The following is a description of a gene set: Ageing of the brain leads to impairments in cognitive and motor skills, and is the major risk factor for several common neurological disorders such as Alzheimer disease (AD) and Parkinson disease (PD). Recent studies suggest that normal brain ageing is associated with subtle morphological and functional alterations in specific neuronal circuits, as opposed to large-scale neuronal loss. In fact, ageing of the central nervous system in diverse mammalian species shares many features, such as atrophy of pyramidal neurons, synaptic atrophy, decrease of striatal dopamine receptors, accumulation of fluorescent pigments, cytoskeletal abnormalities, and reactive astrocytes and microglia. To provide the first global analysis of brain ageing at the molecular level, we used oligonucleotide arrays representing genes to determine the gene-expression profile of the ageing neocortex and cerebellum in mice. Ageing resulted in a gene-expression profile indicative of an inflammatory response, oxidative stress and reduced neurotrophic support in both brain regions. At the transcriptional level, brain ageing in mice displays parallels with human neurodegenerative disorders. Caloric restriction, which retards the ageing process in mammals, selectively attenuated the age-associated induction of genes encoding inflammatory and stress responses. Mouse Gene Set: LEE_CALORIE_RESTRICTION_NEOCORTEX_UP species: Mus musculus from publication Lee CK, Weindruch R, Prolla TA (PMID 10888876) Up-regulated in the neocortex of aged (30-month) mice subjected to caloric restriction since young adulthood., and this is the list of marker genes: Anxa6, Slc12a2, Pura, Hint2, Naa80, Zfp771, Zbtb7a, Lonp1, Gpr19, Samhd1, Gabra2, Acta1, Stk39, Hoxa6, Khdrbs1, Hoxb9, Slc6a15, Cnot2, Hoxb3, Dtna, Tnnc1, Fabp5, Tyms, Osbp2, H2-M3, Uba7, Ces1c, Prkd1, Atp13a2, Mtif2, Gja3, Umps, Kmt2b, Drd4, Nprl2, Ppic, Mcpt4, a, Ifna5, Oprd1, Pole3, Selp (NCBI Gene Id 20344), Klc1, Prl2b1, Cblif, Aqp4, Pf4, Tle1, Maff, Tsc22d1 (NCBI Gene Id 21807), Msh2, Serpine1, Relb, Thbs3, Bag6, Bmp1, Ppef2 (NCBI Gene Id 19023), Edn2, E4f1, Ldb1, Ptprd, Tfdp1, Csk, H2-T3, Pcna, 2510039O18Rik, Nfkbia, Cit, Gata4 (NCBI Gene Id 14463), Eif2ak3, Gas6